The following is a description of a gene set: Mouse Gene Set: GOBP_POSITIVE_REGULATION_OF_ORGANELLE_ORGANIZATION Any process that increases the frequency, rate or extent of a process involved in the formation, arrangement of constituent parts, or disassembly of an organelle. studied in species Mus musculus, and this is the list of marker genes: Entr1, Nck2, Smpd3, Wasf2, Mapk9, Sh3pxd2b, Doc2g, Snx7, Tgfb3, Map1b, Fes, Cnot6l, Synj1, Snca, Rab3gap1, Dstn, Zdhhc6, Micu1, Ddhd2, Smc5, Mlst8, Dnm1l, Actr3, Ccl24, Parn, Add3, Igf1r, Terc, Msx2, Smc4, Prkcq, Anapc5, Bik, Tnfsf10, Mecp2, Ncapd3, Potefam3a, Znrf1, Actr5, Tmed9, Id1, Rgcc, Eif4g3, S100a10, Cenpj, Irgm2, Mfn1 (mitofusin 1), Tapt1, Gper1, Bak1, Plk4, Lmod2, P2rx7, Ube2b, Pdlim4, Fhod1, Xrcc5, Fyco1, Mtor, Dcn, Ereg, Cnot1, Ppp1r35, Togaram1, Ccl21d, Saxo1, Igf1, Pxn, Tsc1, Lrp5, Atmin, Lrsam1, Endog, Potefam3b, Tnks, Hmbox1, Mapk8, Nes, Tnks2, Becn1, Tgfa, Ctnnb1, Lpar1, Syt13 (NCBI Gene Id 99017), Rph3al, Terf2, Slain1, Ino80, Dzip1, Pan2, Pnkp, Wipi1, Cd28, Piwil2, Ccl21e, Atm, Mre11a, Gch1, Mtss1, Pfn5, Bnip3, Pdgfb, Ulk1, Igtp, Htt, Hrk, Slx1b, Pycard, Acd, Cct6a, Tmem67, Gnl3, Sirt2, Cep135, Sorbs3, Bcl2l11, Wasf1, Rad50, Spast, Grn, Tnf, Ubap2l, Mcoln1, Sass6, Rab11fip3, Vps4b, Fuz, Crocc, Vasp, Syt3, Ccdc15, Rab3ip, Smc2, Epgn, Cx3cl1, Rad51ap1, Bub1, Abi2, Anxa1, Cep120, Csf2, Trim27, Syt5, Fam162a, Lcp1, Syt2, Yme1l1, Fgf8, Met (met proto-oncogene), Tac1, Lmod1, Shcbp1l, Rac1, Dazl, Dmrt1, Synpo2, Drd3, Stx18, Magel2, Insr, Plek, Opa1, Pla2g4a, Lnpk, Pla2g6, F2rl1, Cenpe, Edn1, Hnrnpd, Dkc1, Pip4k2b, Mark4, Wnt3a, Ncapg2, Kif5b, Rala, Ska3, Ank1, Slf2, Hspa1b, Bag4, Pink1, Ccl21b, Ncaph, Cfl2, Pld6, Syt4, Caprin1, Katnb1, Msn, Erc2, Nvl, Ccn2, Fen1 (flap structure specific endonuclease 1), Rictor, Synpo2l, Prkce, Syt7, Rock2, Scin, Abl1, Cdc42ep1, Septin9, Bmp10, Dhx36, Fas (Fas cell surface death receptor), Wrap53, Hspa1a, Macroh2a1, Pgam5, Carmil1, Ankrd53, Psrc1, Apoa1, Ckap5, Sfpq, Nup62, Irgm1, Cdk1, Cdc20, Mcrs1, Tpr, Mapt, Nphs1, Zfp13, Lig4, Prrt2, Ssbp1, Cfl1, Mul1, Vps35, Bid, Wdr45, Trim32, Zmynd10, Gsk3b, Il5, Cacna1b, Ins1, Cav3, Pfn1, Npr2, Arhgef15, Bbs4, Cnot6, G3bp2, Mllt11, Nsmce2, Pml, Sdc1, Apc, Ift88, Cdc42ep5, Myo1c, Snx4, Pot1a, Pfn2, Mief2, Pdcd5-ps, Plcb1, Pqbp1, Pmaip1, Abcg1, Atg5, Baiap2l2, Ccl21a (C-C motif chemokine ligand 21 (serine)), Brk1, Carmil2, Aurkb, Ncapg, Sgo2a, Marchf5, Cdc42ep4, Egf, Wdr35 (WD repeat domain 35), Gda, Katnbl1, Atrx, Pip4k2a, Calcoco2, Limch1, Cdk5rap2, Stra8, Hap1, Tacr1, Cracd, Pde4dip (NCBI Gene Id 97109), Ankrd66, Chchd10, Tenm1, Fer, Rps3, Smcr8, Baiap2l1, Numa1, Wnt4, Gja1, Moap1, Csf3, Sh2b1, Ccl11, Akap9, Nabp2, Ddx11 (DEAD/H box helicase 11), Dync1h1 (NCBI Gene Id 319904), Kat5, Ccl26, Cul3, Pkib, Anapc7, Gsn, Wmp, Pip4k2c, Stil, Cdc42, Ino80b, Rb1, Git1, Ooep, Msx1, Clip1 (CAP-GLY domain containing linker protein 1), Limk1, Cyfip1, Sphk1, Swap70, Ercc1, Spire1, Cdk2, Mcu, Rapgef3, Naf1, Stmn2, Cct8, Klf4, G3bp1, Cdc16, Pak1, Dynll1, Arhgef10l, Kctd17, Cdc42ep2, Ift20, Nav3, Adck1, Mtnap1, Cct7, Ep300, Rph3a, Slain2, Arf6, Map3k1, Rad21, Il1b, Poc1b, Pebp1, Doc2b, Ruvbl1 (RuvB-like AAA ATPase 1), Clec16a, Hsf1, Sdcbp, Sh3glb1, Pdcd6ip, Ppm1f, Hoxa13, Tcp1, Myc, Elapor1, Prox1, Mapre1, Fchsd2, Doc2a, Camk2b, Drg1, Gpr65, Tal1, Btc, Pfn3, Nckap1, Anapc11, Fscn1 (fascin actin-bundling protein 1), Pan3, Rhoc, Bad, Ppp3cb, Nfrkb, Fis1, Arl2, Plaur, Hip1r, Tpm1, Serpinf2, Hnrnpa2b1, Nbn, Ralbp1, Adrb2, Rtel1, Pdxp, Fermt2, Erc1, Cdc23, Nek7, Ptges3, Sdc4, Atr, Tom1, Nox4, Epha1, Ncapd2, Prap1, Anxa2, Wasf3, Trp53, Mad2l1bp, Ube2c, Syt8, Ptk2b, Cd47, Icam1, Rimbp2, Atl3, Ttbk2, Nck1, Igf2, Ccp110, Itgb1bp1, Cttn, Siva1, Arhgap35, Baiap2 (NCBI Gene Id 97767), Syt1, Src, Cdkn1b, Pla2g5, Grb2, Terf1, Actr8, Mylk3, Pdgfrb, Ncaph2, Rims1, Kirrel1, Dlg1, Cav1, Edn3, Cdc42ep3, Prkd1, Ska1, Atp5if1, Ins2, Alox15, Rhoa, Mapk15, Gsk3a, Pfdn2, Mns1, Actl6a (NCBI Gene Id 99742), Lman1, Braf, Meiosin, Cnot2, Htr1a, Aurka, Synpo, Cct2, Plxna3 (plexin A3), Prkn, Spag5, Snx18, Wnt11, Nrp1, Kdr, Tgfbr1, Cct5, Surf4, Mff, Znrf2, Ralb, Fbxo5, Nek2, Arhgef5, Sema5a, Cep295, Ccl21f, Nckap1l, Cct4, Phip, Ppp1r10, Osbp, Ddhd1 (DDHD domain containing 1), Atg2a, Rp1, Rab3gap2 (NCBI Gene Id 98732), Syt9, Ccdc88a, Nusap1, Slx4, Tinf2, Arpc2, Mmp9, Map3k4, Vil1, Fmn1, Bax, Cct3, Fchsd1, Il1a, Terf2ip, Pdcd5, Mapk1, Gm14137, Wnt5a, Bok, Tfpt, Whamm, Sirt6, Fbxo4, Uchl5, Actn2, Mapk3, Ptbp1, Map2k7, Kiss1r, Mapkapk5, Ruvbl2, Wrap73, Gpsm2, Snx9, Tesk1, Hif1a, Prdm9, Mad1l1, Bmf, C2cd5, Flna, Bin1, Myoc (myocilin), Rims2, Yy1, Ino80c, Npm2, Evl, Pot1b, Mief1, Bbc3, Arhgef10, Trpv4, Wdr1, Snx30, Dctn1, Nf2, Slf1, Smad3, Syt11, Ppm1e, Ino80d